The following is a description of a gene set: species: Mus musculus The aggregation, arrangement and bonding together of a set of components to form an excitatory synapse. Mouse Gene Set: GOBP_EXCITATORY_SYNAPSE_ASSEMBLY, and this is the list of marker genes: Ptpn13, Nrxn3, Il1rap, Lrrtm2, Reln, Ptk2b, Prickle1, Abi3bp, Lrfn1, Sema4a, C1ql2, Cbln1, Nptx1, Ptprs, Lrfn4, Srgap2, Caskin1, Fgfr1, Lats1, Nlgn2, Wnt7a, Slitrk3, Clstn3, Prickle2, Abi3, Nptn, Plxnb2, Zdhhc12, Pten, Nlgn1, Lrrc4b, Ntrk3, Shank3 (SH3 and multiple ankyrin repeat domains 3), Sipa1l1, Ptprd, Nrxn2, Csmd2, Cntnap2, Grid2, C1ql3, Lrrc4, Lrrtm1, Vstm5, Nrxn1, Cript